Given this list of marker genes Nup205, Pcgf2, Sumo1, Scmh1, Aaas, Hnrnpk, Nup133, Nup58, Nop58, Cbx2, Cbx4, Ring1, Nup85, Nup210, Nup42, Ndc1, Nup93, Bmi1, Nup155, Cbx8, Seh1l, Phc1, Nup54, Rae1, here is a description of the gene set: part of: SUMO E3 ligases SUMOylate target proteins Reactome Pathway: SUMOylation of RNA binding proteins species: Mus musculus electronically inferred by orthology from the curated human pathway This event has been computationally inferred from an event that has been demonstrated in another species.<p>The inference is based on the homology mapping from PANTHER. Briefly, reactions for which all involved PhysicalEntities (in input, output and catalyst) have a mapped orthologue/paralogue (for complexes at least 75% of components must have a mapping) are inferred to the other species.